Given this list of marker genes Nubp1, Hyal2, Aplp2, Cyp27b1, Wnk1, Cnnm3, Edn1, Iscu, Enpp1, Agt, Spp1, P2rx7, Slc30a5, Tmco1, Tgfb2, Ghitm, Umod, Jph2, Mir17, Pth, Atp13a1, Ctrc, Micu3, Hcrtr2, Fgfr4 (NCBI Gene Id 212063), Cnnm2 (NCBI Gene Id 94219), Pacs2, Tex101, Ero1a, Plcd1, Tmc8 (NCBI Gene Id 276788), Eif3e, Npsr1, Trpc5, Tmem165, Ccl19-ps4, Stk39, Ifng, Cacnb4, Hps1, Zng1, Herpud1, Cdh23, Trim24 (tripartite motif-containing 24), Mecr, Grin2b, Bak1, Apoe, Atg5, Calb2, Rhcg, Kcna1, Cul5, Otc, Cd19, Atp2a1, Drd4, Npy, Abcb6, Sgcd, Gcm2, Mtln, Sfrp4, Fth1, Diaph1, P2ry1, Chd7, Tmem178, F2rl3, Sgk1, Fxyd1, Glul, Wfs1, Comt, Hamp, Slc39a13, Ccr1l1, Acvr2b, Steap3, Plcb4, Smad5, Slc1a3, Cemip, Tunar, Trpc6, Ntsr1, Lyn (NCBI Gene Id 99963), Slc9b2, Scnn1b, Hamp2, Cnr1, Slc25a23, Psen2, Stc2, Flna, Dmtn, Atp2a2, P2ry6, Neo1, Hfe, Letm1, Cd40, Osbpl2, Selenon, Alas2, Kcnh1, Tesc, Tspoap1, Kcnj10, Calm3, Grina, Nt5e, Smad1, Mon1a, Stim2, Tmem38b, Fgfr3, Ccr5, Ank3, Slc39a14, Itpr2, Atp1a3, Fcrl5, Htr2a, Calb1, Atp2b1, Ncoa4, Gp5, C7, Sco2, Rmdn3, Cybrd1, Atp4a, Cp (NCBI Gene Id 51906), Jsrp1, Mcoln1, Klhl3, Slc8a1, Slc30a7, Slc34a2, Smdt1, Slc31a2, Slc30a8, P2ry2, Tmem38a, Ryr3, Rhbg, Mllt6, Smad4, Cacna1a, Hif1a, Anxa7, Scara5, Meltf, Immt, Pdzd8, Hexb (hexosaminidase B), Nptn, Cav3, Ryr1, Ptprc, Cst5, Sv2a, Disc1, Ccl21d, Pthlh, Ccl19-ps6, Stim1, Xpr1, Pik3cb, Cib2, Plcb2, Fech, Dbi, Tgfb1, Mettl21c, Ibtk, Tpcn2 (NCBI Gene Id 233979), Slc12a1, Casq1, Sppl2c, Nherf1, Tmem64, Hrc, Ryr2 (NCBI Gene Id 77553), Afg3l2, Plcl2, Snca, Cav2 (caveolin 2), Tmprss6, Atp6v0a2, Cx3cl1, Wnk4, Atp7b, Tmtc2, Itpr1, Plcg1, Slc1a1, Aplnr, Fgfr1, Adcy8, Ndfip1, Slc41a1, Trdn, Slc40a1, Tgm2, Fzd9, Gpr12, Plch2, Plce1, Mir122, Trpc3, Tnfsf11, Grin1, Calm1, Fgf2, Agtr2, Marcksl1, Kdr, Cacna1f, Ubash3b, Camk2d, P2ry4, Pkhd1, Tmc6 (NCBI Gene Id 52547), Ckb, Tbxas1, Slc17a8, Atp1b1, Kcne3, Casq2, Epas1, Cnnm4, Glp1r, Csrp3, Tfr2, Cxcl9, Fasl, Ednrb, Nr3c2, Slc12a5, Kcnma1, Trpv4, Prkcb, Ccl19-ps5 (NCBI Gene Id 100039789), Efhc1, Gdf2, Kcna5, Erfe, Abcb7, Fam20a, Tfrc, Cacna1d, Myo5a, Ccl19, Frey1, Prkce, Pdpk1, Aco1, Trpc1, Trpa1, Cyb561a3, Pln, Clcc1, Slc12a4, Atp1a2, Ftl1, Slc34a1, Htt, Slc12a7, Fam3a, Bok (NCBI Gene Id 98569), Slc30a9, Mfn2, Corin, Upk3a, Arf1, Dmpk, Myh7b, Sod1 (superoxide dismutase 1, soluble), Scnn1g, Ccl2, Cngb1, Synpo, Sod2, Slc30a10, Cln3 (NCBI Gene Id 12752), Slc24a5, Ngf, Clstn1, Cherp, Gp9, Slc8a3, Slc17a7, Glrx3, Ms4a2, Slc39a7, Cnga1, Ccl21f (C-C motif chemokine ligand 21F), Plcb3, Plcl1, Slc30a1, Stoml2, Lck, Atp6v1a, Micu2, Atp6ap1, Trpv6, Ccl19-ps3, Mt1, F2r, Itpr3, Cxcl11, Selenok, Vapb, Slc9a1, Cisd1, Abl1, Casr, Xcl1, Kctd17, Ext2, Myc, Sco1, Ptpn6, Mcur1, Mtss1, Hmox1, Prkca, Fxyd2, Slc17a6, Xcr1, Fate1, Edn2, Trpv5, Hjv, Atp2b2, Atp1a4, Ptk2b, Npy1r, Trmt10a, Hap1, Slc12a6 (NCBI Gene Id 93718), Thy1, Mcu, Slc11a2, Bmyc, Mt2, Cib3, Ccdc22, Maip1, Hmox2, Lcn6, Stc1 (NCBI Gene Id 20855), Cyba, Htr2c, Sypl2, Lcn2, Kel, Steap4, Atp13a5, Epb42 (erythrocyte membrane protein band 4.2), Trpm8, Ccl3, App, Tcirg1, Erc1, Ccl19-ps1, Pml, Gpr39, Scnn1a, Bnip3, Slc12a8, Ank2, Psen1 (NCBI Gene Id 19164), Ncs1, Micu1, Fbxl5, Bmp6, Slc30a2, Cacna1s, Rhag, Atp1a1, Trpc7, Pygm, Grm1, Slc10a7, Itgb3, Sv2b, P2rx2, Plcg2, Fto, Gper1, Kl, Cnnm1, Rgn, Plcb1, Coro1a, Atp2c1, Scn7a, Atp13a3, Slc39a10, Ap3b1, Edn3, Slc24a1, Pkd2, Atp1b3 (NCBI Gene Id 11933), Plch1, Tmem203 (transmembrane protein 203), Cox19, Cdh5, Gp1ba, Trpm2, Cdk5, Calcb, Hephl1, Slc8b1, Inpp4b, Slc37a4 (solute carrier family 37 (glucose-6-phosphate transporter), member 4), Ccr1 (NCBI Gene Id 12768), Picalm, Alpl, Fkbp1a, Steap2, Hpx, Il13, Atp2c2, Tmprss3, Fxn, Abcc2, Grik2, Slc39a9, Hoxa3, Bax (BCL2-associated X protein), Rimbp2, Xk, Atp2a3, Wnt5a, Bcl2, Slc31a1, Akap6, Slc39a6, Kcnq1, Cacna1c, Slc12a9 (solute carrier family 12 (potassium/chloride transporters), member 9), Ddit3, Gsto1, Atp7a, Calca, Asph, Rnls (renalase, FAD-dependent amine oxidase), Ccl21b, 1600014C10Rik, Ccdc115, Anxa6, Thada, Tmem199, Frrs1, Ccr2, Eif2ak1, Fkbp1b, Mc3r, Ednra, Atp13a4, Slc24a4, Dmd, P2rx1, Slc8a2, Mt4, Atp6v1b1, Ywhae, Spx, Drd2, Atp12a, Lhcgr, Slc39a8, Tmtc4, Bola2, Atp2b4, Trf, Slc11a1, Ttc7, Trpc2, Itgav, Ccl5, Ptk2, S100b, Ext1, B2m, Slc39a4 (solute carrier family 39 (zinc transporter), member 4), Drd3, Calm2, Cav1, Kctd7, Fthl17e, Nppc, Capn3, Atp13a2, Ftmt, Slc24a2, Mcub, Cox10, Atp6v0d1, Sri, Trpc4, Cacnb2, Bdkrb1, Tnni3, Atp6v1g1, Mt3, Rap1gds1, Jph3, Btbd9, Naglu, Htr2b, Ccl8, Ank1, Snx10, Letmd1, Dhrs7c, Atp1b2, Ank, Atf4, Ccdc47, Ankrd9, Enpp3, Rhd, Erc2, Ccl21e, Hcrtr1, Chga, Gp1bb (NCBI Gene Id 14724), F2, Vps54, Tmbim6, Ccl21a, Slc12a3, Prnd, Slc39a5, Cxcr3, Slc35g1, Ireb2, Htr1b, Atp4b, Gpr3, Kcnh2, Slc34a3, Cxcl10, Nucb2, Slc24a3, Znhit1, Fgf23, Tmem174 (transmembrane protein 174), Slc12a2, Atp2b3, Atox1, Trpm7, Adora1, Car12, Bsnd, Prnp, Lime1, Slc25a27, Il1a, Egln1, Commd1, Slco2b1, Clec4b1, Cyb561, Pth1r, Tmem94, Nol3, Heph, Drd1, Prkd1, Vdr, Abcc6, Grid2ip, Pde4d, Gstm7, here is a description of the gene set: Any process involved in the maintenance of an internal steady state of inorganic ions within an organism or cell. species: Mus musculus Mouse Gene Set: GOBP_INORGANIC_ION_HOMEOSTASIS